The following is a description of a gene set: The asymmetric division of cells to produce two daughter cells with different developmental potentials. It is of fundamental significance for the generation of cell diversity. Mouse Gene Set: GOBP_ASYMMETRIC_CELL_DIVISION studied in species Mus musculus, and this is the list of marker genes: Rab10, Arhgef2, Golga2, Stra8, Dock7, Zbtb16, Rgs14, Ing2, Etv5, Aspm, Actr2, Dicer1, Pax6, Actr3, Fgf13, Cntrl, Wnt9b, Tead3, Pou5f1, Insc (INSC spindle orientation adaptor protein), Sox5